The following is a description of a gene set: Human Gene Set: GOBP_TRIGLYCERIDE_RICH_LIPOPROTEIN_PARTICLE_CLEARANCE The process in which a triglyceride-rich lipoprotein particle is removed from the blood via receptor-mediated endocytosis and its constituent parts degraded. species: Homo sapiens, and this is the list of marker genes: LIPC, APOC3, GPIHBP1, APOC1, LIPA, APOC2, APOE, LMF1